Given this list of marker genes Mrpl32 (NCBI Gene Id 75398), Mrpl27, Oxa1l, Mrps26, Mrpl2, Mrps33, Mrpl15, Mrpl17, Mrpl16, Mrpl21, Mrpl1, Mrpl58, Mrpl14, Aurkaip1, Mrpl28 (mitochondrial ribosomal protein L28), Mrpl36, Mrps35, Mrpl57, Mrpl40, Mrpl47, Mrps17, Mrpl34 (NCBI Gene Id 94065), Mrpl4, Mrpl3, Mrps18c, Mrps6, Mrps12, Mrpl52, Mrps16, Mrps36, Mrpl22, Mrpl23, Mrpl54, Mrpl13, Mrpl35, Mrps21 (NCBI Gene Id 66292), Mrpl33, Mrps7, Mrpl55, Mrpl53, Mrpl11, Mrpl51, here is a description of the gene set: species: Mus musculus part of: Mitochondrial translation Reactome Pathway: Mitochondrial translation elongation electronically inferred by orthology from the curated human pathway This event has been computationally inferred from an event that has been demonstrated in another species.<p>The inference is based on the homology mapping from PANTHER. Briefly, reactions for which all involved PhysicalEntities (in input, output and catalyst) have a mapped orthologue/paralogue (for complexes at least 75% of components must have a mapping) are inferred to the other species.